The following is a description of a gene set: studied in species Mus musculus Mouse Gene Set: GOMF_CYSTEINE_TYPE_EXOPEPTIDASE_ACTIVITY Catalysis of the hydrolysis of C- or N-terminal peptide bonds in a polypeptide chain by a mechanism in which the sulfhydryl group of a cysteine residue at the active center acts as a nucleophile., and this is the list of marker genes: Actmap, Blmh, Ctsl, Mindy1 (MINDY lysine 48 deubiquitinase 1), Scrn2, Scrn1, Ctsz, Atg4d, Mindy2, Scrn3